The following is a description of a gene set: This study set out to identify global changes in gene expression in AGS gastric epithelial cells following 8 hours stimulation with 10 μg/ml lipopolysaccharide (LPS) from the gastric pathogen H. pylori. Microarray analysis was used to compare changes in gene expression between cells treated with 10 μg/ml H. pylori LPS and untreated cells at the same time point. species: Homo sapiens Genes up-regulated in AGS cells (gastric adenocarcinoma): control versus H. pylori LPS. from publication Smith SM, Moran AP, Duggan SP, Ahmed SE, Mohamed AS, Windle HJ, O'Neill LA, Kelleher DP (PMID 21220698) Human Gene Set: GSE25146_UNSTIM_VS_HELIOBACTER_PYLORI_LPS_STIM_AGS_CELL_UP, and this is the list of marker genes: MDM2, CDC16, ANKRD16, ARHGAP19, GANAB, CYP20A1, USP15, USP37, MCM4, MIS18BP1, SUV39H1, UHRF1, KIF15 (NCBI Gene Id 56992), SRSF6 (NCBI Gene Id 6431), THY1, RNF170, MLH1, BRCA1, PREB, WDR62, GMEB2, GBP5, TGDS, FAM193B, RTF1, G2E3, CENPH (NCBI Gene Id 64946), TAF1, CHTF18, EME1, CASP4, TAF1D, DYNLL2, PPM1J, MAGI3, RACGAP1, RASGRP2, MAN1B1, WDR82, RASGRP1, NDC1 (NCBI Gene Id 55706), PLXNC1, ATAD2, ACAP1, DEPDC1, RPRD1A, PRPF3, PPOX, PIF1, PIH1D1, GRK5, NCLN, SGO2, GNPTAB, MAP3K7, RBM15, REXO4, ARHGAP30, NCAPD3, ING1, BMPR1A (NCBI Gene Id 8035), PLK1, DNA2, G3BP1, SNRNP70, ZBTB41, ZMYND11, SRSF7, BAIAP3, THAP3, SGO1, GDI1, ESCO2, CKAP2L, GRAMD1A, IFITM2, FAM76B, TRAP1, PRKAR2B, CENPI, MLEC, PANK3, CDKN2C, DNM1L, GPSM2, CMPK2, ESPL1, DDX46, GZF1, ACIN1, H1-1, TUBGCP4, BCLAF1, GALNT7, SAMD3, IRAG2, HELLS, RFK, ATAD5, FBXO48, RTEL1, PIK3C2A, NCAPD2, PTPN7, ENTR1, RAF1, TPR, SBF1, USP5, IKBKE, HNRNPH1, CDK16, BTK, RAD51, NOP58, ELMOD2, SOAT2, IVNS1ABP, PLOD2, SUPT20H, CENPL, NAA35, ENTPD1 (NCBI Gene Id 953), E2F8 (NCBI Gene Id 79733), PDE4D (NCBI Gene Id 654081), SLC4A2, IL12RB2, HNRNPU, ZCRB1, TRPV2, PAPOLA, WDHD1, DZIP1, CNIH4 (NCBI Gene Id 29097), CIT, RRM2, CXCL13, SSR3, NCAPH, CD99L2, UTP20, SEC24C, TOE1, CEP95, BAZ1A, DHX30, AIFM1, RASGRP3, TEP1, PCGF6, PTPN9, DYNC1LI2, AGTPBP1, ANLN, ZMYM5, CLCN7, MTO1, CPSF1, CYP17A1, SC5D, TMPRSS13, ARHGAP45, DGCR8, CKAP5 (cytoskeleton associated protein 5), KIF4A, ADAMTS10, TXLNA, SEMA4A, TNPO2, PTPN12, SMPDL3B, POLA2, MAPK8IP3, PHF11, RNF4, GTF3C4, MPHOSPH9, MTMR4 (NCBI Gene Id 9110), NELFCD, FYCO1